Given this list of marker genes SLC22A13, SLC2A9, ABCC4, SLC17A4, SLC23A1, SLC17A2, SLC17A3, SLC22A12, ABCG2, here is a description of the gene set: Human Gene Set: GOMF_SALT_TRANSMEMBRANE_TRANSPORTER_ACTIVITY Enables the transfer of salt from one side of a membrane to the other. species: Homo sapiens